The following is a description of a gene set: Pathway Definition from KEGG: PDYN* -> NMDAR -> Ca2+ Human Gene Set: KEGG_MEDICUS_VARIANT_MUTATION_CAUSED_ABERRANT_PDYN_TO_TRANSPORT_OF_CALCIUM Mutation-caused aberrant PDYN to transport of calcium. Pathway ID: N00971. Pathway type: Variant. Pathway class: nt06462 Spinocerebellar ataxia. studied in species Homo sapiens, and this is the list of marker genes: GRIN2A, PDYN, GRIN2D, GRIN2C, GRIN1, GRIN2B